The following is a description of a gene set: species: Homo sapiens Human Gene Set: HP_INCREASED_MUSCLE_LIPID_CONTENT Increased muscle lipid content An abnormal accumulation of lipids in skeletal muscle., and this is the list of marker genes: MSTO1, KCNE3, MIPEP, MYH7, COL6A1, CACNA1S, MT-TN, KBTBD13, KLHL41, HMGCR, MYPN, ISCU (iron-sulfur cluster assembly enzyme), SELENON, NDUFS4, COQ8A, TTN, GABRA3, COL6A2, TPM3, SURF1, CPT2, ABHD5, COL6A3, ACTA1, COL12A1, TPM2, SCN4A, NDUFA4 (NDUFA4 mitochondrial complex associated), CHCHD10, PNPLA2, TRMU, NEB, MT-TE, AFG3L2, KCNJ18, SUCLG1, STAC3, COX6A2, SDHA